Given this list of marker genes TUBA1A, CHEK1, UTRN, CCNA2, H4C3, NAB2, UNG, UBE2C, PPP1R7, ADCY3, PLK1, here is a description of the gene set: Human Gene Set: CHUANG_OXIDATIVE_STRESS_RESPONSE_DN Genes down-regulated in MCF7 cells (breast cancer) after treatment with the oxydants: hydrogen peroxyde, menadione, and t-butyl hydroperoxyde. Global gene expression patterns in breast cancer cells after treatment with oxidants (hydrogen peroxide, menadione, and t-butyl hydroperoxide) were investigated in three replicate experiments. RNA collected after treatment (at 1, 3, 7, and 24 h) rather than after a single time point, enabled an analysis of gene expression patterns. Using a 17,000 microarray, template-based clustering and multidimensional scaling analysis of the gene expression over the entire time course identified genes as being either up- or down-regulated by the three oxidants. In contrast, only genes were identified for any single time point and a 2-fold change criteria. Surprisingly, the patterns of gene induction were highly similar among the three oxidants; however, differences were observed, particularly with respect to p53, IL-6, and heat-shock related genes. Replicate experiments increased the statistical confidence of the study, whereas changes in gene expression patterns over a time course demonstrated significant additional information versus a single time point. Analyzing the three oxidants simultaneously by template cluster analysis identified genes that heretofore have not been associated with oxidative stress. studied in species Homo sapiens from publication Chuang YY, Chen Y, Gadisetti, Chandramouli VR, Cook JA, Coffin D, Tsai MH, DeGraff W, Yan H, Zhao S, Russo A, Liu ET, Mitchell JB (PMID 12414654)